The following is a description of a gene set: species: Mus musculus Any process that results in a change in state or activity of a cell (in terms of movement, secretion, enzyme production, gene expression, etc.) as a result of a cAMP (cyclic AMP, adenosine 3',5'-cyclophosphate) stimulus. Mouse Gene Set: GOBP_CELLULAR_RESPONSE_TO_CAMP, and this is the list of marker genes: Dmtn, Zfp36l1, Hcn2, Lncbate10, Itpr2, Akap7, Crtc2, Rap1b, Rplp0, Kdm1a, Aanat, Igfbp5, Slc8a1, Crtc1, Rapgef2, Hcn4, Star, Gpd1, Cps1, Akap9, Cftr, Inhbb, Rap1a, Ezr, Kcnq1, Pde4d, Kcne1, Slc26a3, Gata1, Itpr3, Aqp8, Inpp5k, Cyp1b1, Adipoq, Aqp1, Itpr1, Slc26a6, Eef2k, Stc1, Hcn1, Rapgef1, Ptafr, Pck1, Ass1, Pde2a, Ahr, Slc8a3 (solute carrier family 8 (sodium/calcium exchanger), member 3), Rapgef3, Penk, Pik3cg, Crtc3, Fbp1, Akap6, Pkd2, Crhbp, Wnt10b, Fdx1